The following is a description of a gene set: Choriocarcinoma Human Gene Set: HP_CHORIOCARCINOMA studied in species Homo sapiens A malignant, trophoblastic and aggressive cancer, usually of the placenta. It is characterized by early hematogenous spread to the lungs and belongs to the far end of the spectrum of gestational trophoblastic disease (GTD), a subset of germ cell tumors., and this is the list of marker genes: CHEK2 (checkpoint kinase 2, NCBI Gene Id 11200), TP53, MDM2, KIT, BCL10, STK11, FGFR3, CDKN2A